Given this list of marker genes Ngb, Mtarc1, Gmpr (guanosine monophosphate reductase), Cbs, Mb, Cyb5r3, Cyp1a2, Uox, Xdh, Gmpr2, Mtarc2, Nqo2, Gphn, Cyb5b, Cygb (cytoglobin), here is a description of the gene set: Mouse Gene Set: GOMF_OXIDOREDUCTASE_ACTIVITY_ACTING_ON_OTHER_NITROGENOUS_COMPOUNDS_AS_DONORS Catalysis of an oxidation-reduction (redox) reaction in which a nitrogenous group, excluding NH and NH2 groups, acts as a hydrogen or electron donor and reduces a hydrogen or electron acceptor. studied in species Mus musculus